Given this list of marker genes Oas1d, Sirt1, G6pc2, Hmga1, Fbn1, Mir337, Becn2, Adra1b, Neurod1, Abcg1, Gpi1, Pdk4, Ptch1, Hkdc1, Map4k4, Slc12a7, Pdx1, Gcgr, Col1a1, Pde4c, Eny2, Pax2, Foxk2, Adipor1, Lrrc8d, Gpr68, Rack1, Slc29a1, Grk2, Xbp1, Ccl2 (C-C motif chemokine ligand 2), Vsnl1, Slc16a1, Kif5b, Mup11, Mir130a, Cacna1e (calcium channel, voltage-dependent, R type, alpha 1E subunit), Cyp7a1, Ier3ip1, Mup5, Aspscr1, Klf7, Socs6, Cnr1, Abcc8, Slc2a4, Rab34, Srf, Gck, Mpc2, Trpv4, Aacs, Hmgn3, Oas1c, Crh, Sidt2, Adgrf5, Lep, Piwil4, Lrp5, Pomc, Tunar, Hectd4, Csmd1, Gprc5b, Slc2a2, C2cd2l, Gk, Mup1, Cftr, Obp2a, Ptpmt1, Pik3r2, Ncor2, Slc8b1, Pygl, Ern1, Gcg, Smad4, Ncoa5, Rbp4, Mir192, Pik3r1, Pla2g6, Th, Insr, Cdk16 (NCBI Gene Id 18555), Sesn3, Slc37a4, Oas1g, Rph3al, Cry1, Vcam1, Gclc, Ins2, Ghrl (NCBI Gene Id 80454), Mir532, G6pc1, Sin3a, Or4m1, Tbc1d1, Adissp, Ptprv, Star, Gclm, Smarca4, Sucnr1, Camk2n1, Twnk, Slc12a6, Ffar2, Jagn1, Rraga, Rps6, Trem2 (triggering receptor expressed on myeloid cells 2), Stxbp4, Pde1c, Stk11, Park7, Hnf1a, Ccn4, Ffar3, Ace, Hk2, Oas1e, Kcnj11, Ang2 (NCBI Gene Id 11731), Cry2, Stx4a, Rab11b, Fgfr4, Adcy8, C1qtnf12, Ptpn11, Irs2, Ptpn2, Mir379, Rac1, Cartpt, Mir410 (microRNA 410), Ins1, Bhlha15, Ngfr, Sybu, Sesn2, Ptprn, Adipor2, Myt1, Tsc22d4, Hk3, Mir320, Ero1b, Aqp4, Spop, Dusp29, Bglap, Ncoa6, Oas1f, Cav3, Usf2, Slc30a8, Casr, Nucks1, Slc39a14, Pfkm, Efna5, Rfx6, Bace2, Pih1d1, Abca12, Lrp1, Mtnr1b, Oas1a, Nox4, Sh2b2, Nr1h4, Unc13b, Il6, Ndufaf2, Gjb6, Vgf, Stxbp5l, Tcf7l2, Brsk2, Pck1, Baiap3, Hcfc1, Adcy5, Appl2, Adra2a, Met, Gpr39, Ptprj, Sstr5, Ffar1, Nptx1, Pde8b, Trpm4, Crhr2, Slc9b2, Rbm4, Pik3ca, Trpa1, Cacna1a, Hif1a, Pde3b, Ager, Pim3, Akt1, Mir27a, Osbp, Endog, Dynll1, Sirt6 (NCBI Gene Id 72769), Lin28a, Gpld1, Gpx1, Fabp5, Bad, Prkn, Smarcb1 (SWI/SNF related, matrix associated, actin dependent regulator of chromatin, subfamily b, member 1), Zbed6, Ucp2, Gpr27, Mlxipl (MLX interacting protein-like), Phkb, Ptprn2, Prkaca, Wfs1, Alms1, Selenot, Stat3, Cebpa, Mir200a, C1qtnf3, Oas1b, Atg7, Cmklr2, Mup4, Gas6, Igf1r, Enpp1, Ano1, Smad3, Foxa1 (NCBI Gene Id 15375), Dmxl2, Foxk1, Pax6, Epha5, Arrb1, Hk1, Ppp3cb, Rmi1, Rab11fip2, Oas1h, Smad2, Prcp, Igf1, Klf15, Ankrd26, Cp, Pdk2, Foxo1, Prkce, Cacna1c, Serpinf1, Lrrc8a, Tent4b, Usf1, Ppard, Sri, Fbn2, Pck2, Pparg, Crtc2, Ccdc186, Mir369 (microRNA 369), Foxo3, Hnf4a (hepatic nuclear factor 4, alpha), Nr1d1, Tjp1, Myh9, Oxct1, Csrp3, Oprk1, Ggcx, Lepr, Ogt, Trpm5, Prkaa1, Kcnb1, Gprc6a, Fcor, Rab11fip5, Hmgcr, Ranbp2 (NCBI Gene Id 353053), Adipoq, Kat5, Gper1, Mustn1, Foxa2, Bglap2, Cdkn2a, Guca2b, Foxa3, Birc5, Plscr3, Blvra, Cyb5r4, Tiam1, Fto, Tgfb1, Nadk, Fkbp1b, Rptor, Apoc3, Fosl2, Sgcb, Tra2b, Mbd5, Gckr, Cacna1d, Dbh, Alox5, Zbtb20, Cltrn, Stxbp3, Mcu, Ppp3ca, Agt, Dhps, Mup2, Inpp5k, Icam1, Prkaa2, Cpb2, Sox4, Raf1, Mup3, Gpr21, Ppp1r3g (protein phosphatase 1, regulatory subunit 3G), Igfbp5, here is a description of the gene set: A homeostatic process involved in the maintenance of an internal steady state of a carbohydrate within an organism or cell. species: Mus musculus Mouse Gene Set: GOBP_CARBOHYDRATE_HOMEOSTASIS